The following is a description of a gene set: The series of events in which a visible light stimulus is received by a cell and converted into a molecular signal. A visible light stimulus is electromagnetic radiation that can be perceived visually by an organism; for organisms lacking a visual system, this can be defined as light with a wavelength within the range 380 to 780 nm. studied in species Mus musculus Mouse Gene Set: GOBP_DETECTION_OF_VISIBLE_LIGHT, and this is the list of marker genes: Opn5, Gnat1, Pde6c, Gnat3, Opn4, Rbp4, Pnpla2, Rho, Ttr, Pcp2, Gnb1, Aipl1, Grk1, Irx6